Given this list of marker genes CASP1, SFN, HSPA1A, EIF4A2, TP53, PIM1, PPP2CB, CENPS, TUBB8B, RNASEL, TUBB8 (tubulin beta 8 class VIII), NUP58, POM121C, PDE12, FANCG, SEC13, TUBB2B, TUBB3, NUP35, PGGT1B, PPP2R1B, GBP3, EIF2AK2, PIN1, TUBB6, PPP2CA, KPNB1, MAP2K6, NUP188, KPNA7, FANCA, BECN1, NUP50, EIF4G1, EIF4G3, KPNA5, TRIM25, UBA7, EIF2S3, TUBA4A, TUBB4A, NUP37, NUP88, OASL, FAAP24, RANBP2, PPP2R1A, TUBB2A, GBP4, TUBA1B, NUP93, GBP1, HSPA8, PPP2R5A, FANCB, NUP85, HSPA1B, PLCG1, NUP62 (nucleoporin 62), TUBB4B, GBP5, MAPK3, CENPX, TUBA4B, EIF4E2, NUP54, IRF3, MX1, NUP210, TUBA3E, CDK1, IKBKG, FANCC, VP3, EIF4G2, NUP155, NUP153, ILF2, PTPN2, UBC, NUP43, UBE2I, TUBB1, EIF2S2, NUP107 (nucleoporin 107), FANCL (FA complementation group L), EIF4E, TUBA1A, AAAS, NUP42, PRKRA (NCBI Gene Id 94716), ABCE1, FANCF, STAT1, DHX9, NUP160, RPS27A, NDC1, KPNA3, SNCA (synuclein alpha), RIGI, FLNB, TPR, GBP2, NUP214, NUP205, EIF4E3, ARIH1, JAK1, KPNA1, POM121, NS, USP18, STAT3, HERC5, Human respiratory syncytial virus A2, complete genome, TUBA8, RAE1, OAS3, FNTA, UBA52, VTRNA2-1, NPM1, UBE2E1, HSPA1L (NCBI Gene Id 3305), tat, ADAR, EIF4A3, FURIN, N, FAAP100, DNAJC3, UBB, NEDD4, gag, EIF2S1, IKBKB, MAVS, MAPT, FANCE (FA complementation group E), PPM1B, UBE2N, HSPA2, ISG15, FLNA, TUBA3D (NCBI Gene Id 150778), TRS1, ACTB, SPHK1, UBE2L6, IFIT1, ILF3, KPNA2, OAS2, MX2, SEH1L, FANCM, NCK1, TARBP2, FAAP20, KPNA4, OAS1, TUBA3C, NUP98, ACTG1, CHUK, DUS2, EIF4A1, TUBA1C, NUP133, TUBAL3, SUMO1, FNTB, here is a description of the gene set: studied in species Homo sapiens Interferons activate JAK–STAT signaling, which leads to the transcriptional induction of hundreds of IFN-stimulated genes (ISGs). The ISG-encoded proteins include direct effectors which inhibit viral infection through diverse mechanisms as well as factors that promote adaptive immune responses. The ISG proteins generated by IFN pathways plays key roles in the induction of innate and adaptive immune responses. part of: Interferon Signaling Reactome Pathway: Antimicrobial mechanism of IFN-stimulated genes